Given this list of marker genes Oxct1, Oxct2b, Acat1, Bdh1, Oxct2a, here is a description of the gene set: Utilization of Ketone Bodies Mouse Gene Set: REACTOME_UTILIZATION_OF_KETONE_BODIES studied in species Mus musculus